The following is a description of a gene set: The aim of this study was to quantify the impact of chimeric Foxp3-GFP protein on the Treg cell transcriptional program. species: Homo sapiens Genes down-regulated in FoxP3-IRES-GFP: NOD T reg (FOXP3+) versus B6 splenocytes. Human Gene Set: GSE37605_NOD_VS_C57BL6_IRES_GFP_TREG_DN from publication Darce J, Rudra D, Li L, Nishio J, Cipolletta D, Rudensky AY, Mathis D, Benoist C (PMID 22579475), and this is the list of marker genes: AKNAD1, EIF1AD, WARS2, OAS2, PRSS12, MAP1LC3A, ADPGK, HOXD1, MRS2, PANK3, TTL, CXXC1, SLC39A12, RARA, TK2, MS4A4A, PRKD3, LGMN, ZDHHC20, CAPN2, DAPK1, SIPA1L1, PRF1, DCUN1D3, MOSPD3, ADH7, CCS, HSD17B4 (NCBI Gene Id 3295), UTP25, LZTS1, MED27, METTL8, DNMT1, HAUS8, IFNGR1, MVD, HPS3, WNT8A, SNED1, CAMK4, ECSIT, CD72, IRAK3, RPL12, TMSB15A, NFE2L2, DNAJC11, ADGRL4, CYTL1 (cytokine like 1), FAM193B, OSTF1 (NCBI Gene Id 26578), PACS1, PUS7L, MCUB, RAB4A, TMEM81, RERE, TTK, TRIM56, ARHGAP29, PDE3B (NCBI Gene Id 5140), THAP7, GLUL, IFNB1, TSSC4, IKZF1, MCTP2, SH3BGRL3, TRIM25, PPP3CA, CRABP2, TCEAL5, HTR5BP, POLI, PEX19, SORT1, PADI6, BMP4, PDLIM1, MAGEB3, PPM1J, SLC39A3, SLC30A7, TNNT3, P2RX6, SNTA1, CASC3, PSMC4, PHYHD1, CTH, LY6D, TMEM176B, CATSPER1, PIK3R1, CAPN8, RNF220, COL11A2, UQCC1, SP2, AVIL, AXIN2 (axin 2), RNF20, TRIM13, MICALL2, TXNRD1, SEL1L2, LPP, MRC2, TMPRSS13, SLC25A16, STOM, TUBGCP3 (NCBI Gene Id 10426), FLOT1, TMOD3, PPP1R3B, ALDH1A2, HNF1B, NUDT11 (nudix hydrolase 11), PMFBP1, TSGA10, SDC3, EFHC1, MYO6, OGFOD2, RTN4RL1, CYB561, NSD3, KEAP1, FLI1, SIX6, ABCA13, PUSL1, GNA11, ING3, SERPINB10, NOS3, LCOR, P2RY14, LIPE, IGDCC4, SFT2D1, VIPR1, RASIP1, PEX10, MTMR10, SMTN, A4GALT, CRYBG1, LGALS9, NRROS, CDC14B, CBLB, OSBPL10